Given this list of marker genes PID1, IL4, NDUFC2, GUCA1ANB-GUCA1A, GUCA1A, TREM2, VCP, PINK1, PRKN, TAFAZZIN, TMSB4X, ENO1, ADCY10, PPARA, MAP2K1, STAT3, here is a description of the gene set: Human Gene Set: GOBP_POSITIVE_REGULATION_OF_NUCLEOTIDE_BIOSYNTHETIC_PROCESS Any process that activates or increases the frequency, rate or extent of the chemical reactions and pathways resulting in the formation of nucleotides. studied in species Homo sapiens